The following is a description of a gene set: Genes down-regulated during transition from G2 (moderately differentiated tumor, infected with HCV) to G3 (poorly differentiated tumor, infected with HCV) in the development of hepatocellular carcinoma. from publication Iizuka N, Oka M, Yamada-Okabe H, Mori N, Tamesa T, Okada T, Takemoto N, Sakamoto K, Hamada K, Ishitsuka H, Miyamoto T, Uchimura S, Hamamoto Y (PMID 15710396) Using high-density oligonucleotide array, we comprehensively analyzed expression levels of genes in 50 hepatocellular carcinoma (HCC) samples with positive hepatitis C virus (HCV) serology (well (G1), moderately (G2), and poorly (G3) differentiated tumors) and 11 non-tumorous livers (L1 and L0) with and without HCV infection. We searched for discriminatory genes of transition (L0 vs. L1, L1 vs. G1, G1 vs. G2, G2 vs. G3) with a supervised learning method, and then arranged the samples by self-organizing map (SOM) with the discriminatory gene sets. The SOM arranged the five clusters on a unique sigmoidal curve in the order L0, L1, G1, G2, and G3. The sample arrangement reproduced development-related features of HCC such as p53 abnormality. Strikingly, G2 tumors without venous invasion were located closer to the G1 cluster, and most G2 tumors with venous invasion were located closer to the G3 cluster (P=0.001 by Fisher's exact test). Our present profiling data will serve as a framework to understand the relation between the development and dedifferentiation of HCC. Human Gene Set: IIZUKA_LIVER_CANCER_PROGRESSION_G2_G3_DN studied in species Homo sapiens, and this is the list of marker genes: S100A13, DAZAP2, LGALS9, PIM2, CYBA, TGFB1, SPINT1, BAZ2A, PPT1